Given this list of marker genes Mthfd2l, Mthfd1, Mthfd2, Gchfr, Atic, Gch1, here is a description of the gene set: Mouse Gene Set: GOMF_CYCLOHYDROLASE_ACTIVITY species: Mus musculus Catalysis of the hydrolysis of any non-peptide carbon-nitrogen bond in a cyclic amidine, a compound of the form R-C(=NH)-NH2, in a reaction that involves the opening of a ring.